Given this list of marker genes TFG, TTC19, HINT1, SMN2, VCP, ATXN10, HSPB1, SMN1, here is a description of the gene set: Limb fasciculations Human Gene Set: HP_LIMB_FASCICULATIONS studied in species Homo sapiens Fasciculations affecting the musculature of the arms and legs.